The following is a description of a gene set: CD4(+)Foxp3(+) regulatory T (Treg) cells originate primarily from thymic differentiation, but conversion of mature T lymphocytes to Foxp3 positivity can be elicited by several means, including in vitro activation in the presence of TGF-beta. Retinoic acid (RA) increases TGF-beta-induced expression of Foxp3, through unknown molecular mechanisms. We showed here that, rather than enhancing TGF-beta signaling directly in naive CD4(+) T cells, RA negatively regulated an accompanying population of CD4(+) T cells with a CD44(hi) memory and effector phenotype. These memory cells actively inhibited the TGF-beta-induced conversion of naive CD4(+) T cells through the synthesis of a set of cytokines (IL-4, IL-21, IFN-gamma) whose expression was coordinately curtailed by RA. This indirect effect was evident in vivo and required the expression of the RA receptor alpha. Thus, cytokine-producing CD44(hi) cells actively restrain TGF-beta-mediated Foxp3 expression in naive T cells, and this balance can be shifted or fine-tuned by RA. Genes down-regulated in comparison of memory CD4 T cells treated with retinoic acid (tretinoin) versus untreated memory CD4 T cells. Human Gene Set: GSE13306_RA_VS_UNTREATED_MEM_CD4_TCELL_DN species: Homo sapiens from publication Hill JA, Hall JA, Sun CM, Cai Q, Ghyselinck N, Chambon P, Belkaid Y, Mathis D, Benoist C (PMID 19006694), and this is the list of marker genes: DDIT4, ENO2, MARCKSL1, KYNU, PKM, CHAC1, IARS1 (isoleucyl-tRNA synthetase 1), FCMR, LY75, JCAD (NCBI Gene Id 57608), MACIR, VLDLR (very low density lipoprotein receptor), TLR7, PRPS1, CRYBG3, FLOT2, BMPR1A, PRDM1, ETV6, RAB34, FUT4, ANKRD50, GPT2, PDK1, PHLDB2, HILPDA, CNN3, TBX21, IL10, EXOSC8, ALDH1L2, PRXL2B, ATF3, ACAT2, ZC3H12D, GCH1, IFITM3, CRYBG1, RBM45 (NCBI Gene Id 129831), CCR7, TIRAP, ST6GAL1, TNFRSF4, STK38L, KCNK6, PAQR3, SNX10, LPIN1, ESYT3, FBXO17, ADM, SMOX, MFSD2A, GCAT, SYNE3, TECTB, TPI1, CIART, MID2, NFIL3, HJURP, NEIL1, MYH3, RMC1, IRF6, PKP2, SCAMP1, DYNLT5, MXRA7, PKIB, MAP3K20, MREG (NCBI Gene Id 55686, melanoregulin), PDPN, EIF4EBP1, VIM, HSPA1B, NUDT11, IL13, DMWD, H1-0, NAPA, GLO1, PRKX, DAPP1, GALK1, PGM1, FZD7, SV2C, C1QTNF12, GYS1, MYO6, SLC3A2, TRIB3, MAP4, NREP, DGLUCY, IL4, IFT81, CYB5R1, EEF2K, PPP2R3A, GADD45A, NEDD4, PYGO2, UACA, SLC25A33, CFLAR, SIAH2, ENO1, RAB33A, ERO1A, DENND5A, NPHP3, CAMK2B, SLC1A4, LAMB2, TP53INP2, PTGS1, OSER1, CEP164, IRF4, GNA13, NEK6, HEMGN, PFKL, TNFSF9, TMF1, MGARP, ZC3H12C, GRIN2B, C9orf72, ANXA2, ZNF131, TMEM38B (transmembrane protein 38B), CGAS, TEX10, SEC61A1 (SEC61 translocon subunit alpha 1), MT1E (NCBI Gene Id 4493), PRR36, MAMDC2, PTGIR, RIPK4, MYO1G, BTLA, CTH, TLE1, AHNAK, SLC7A3, CELA1, H3C4, TNFAIP1, MBOAT2, ABHD18, METTL14, ALDOC, ENC1, IER3, GATA3, IL21, CAPN2, ELOC, SBF2, HPSE (NCBI Gene Id 10855), SLC37A4, SLAMF7, REEP1, GP1BB, DCDC2C (NCBI Gene Id 767840), TENT5C, ERMN, P4HA2, CHD7, SELENBP1 (selenium binding protein 1), ANXA6, TFAP2D, FRMD4B, SNRNP25, RBPJL, PPP1R26, SNHG12 (small nucleolar RNA host gene 12), RXRA, SLC2A1, NDRG1, HK1, GARS1, ARL6IP5, BATF3, MTHFD2, RALA, HLX, NIPSNAP3B, ANTXR2, AVPI1, EGLN3, PPT1, ACVRL1, PPP1R3B, PPME1, IL9, B4GALT5